The following is a description of a gene set: Human Gene Set: MEBARKI_HCC_PROGENITOR_WNT_DN_CTNNB1_INDEPENDENT studied in species Homo sapiens Methods: Liver progenitor cells were incubated in a WNT-enriched microenvironment for 72hrs (200 ng/ml mouse recombinant purified Wnt3A from R&D Systems). Gene pathways dependent on downstream _-catenin were studied by _-catenin knockdown with specific siRNA. Gene pathways blocked by extracellular SFRP-like Wnt inhibitors were studied by co-incubating cells with recombinant purified FZD8_CRD (300 ng/ml, from R&D Systems). Independent culture experiments performed in triplicate include untreated cells or cells incubated with scrambled siRNA or with _-catenin-specific siRNA or with FZD8_CRD, alone or in combination with Wnt3A. Transcriptome of human HepaRG hepatocellular carcinoma liver progenitors in responses to a WNT3A-enriched microenvironment and dissection of pathways dependent on _-catenin and/or blocked by the SFRP-like Wnt inhibitor FZD8_CRD. from publication Mebarki S, Désert R, Sulpice L, Sicard M, Desille M, Canal F, Dubois-Pot Schneider H, Bergeat D, Turlin B, Bellaud P, Lavergne E, Le Guével R, Corlu A, Perret C, Coulouarn C, Clément B, Musso O (PMID 27191501), and this is the list of marker genes: FGD3, PRKAR2B (NCBI Gene Id 5577), GCH1, PNLIPRP3, PLIN4, ITGA8 (integrin subunit alpha 8), HCG9, GSTA7P, LY6D, ABCD2, KRT4, TRMT9B (tRNA methyltransferase 9B (putative)), APOB, FA2H, S100P, DOK7